The following is a description of a gene set: Any process that increases the concentration of calcium ions in the cytosol. studied in species Homo sapiens Human Gene Set: GOBP_POSITIVE_REGULATION_OF_CYTOSOLIC_CALCIUM_ION_CONCENTRATION, and this is the list of marker genes: CX3CR1, LPAR1, CD36, CACNA2D1, AVPR1B, P2RX3, GPR35, FPR1, CD52, ADCYAP1R1, CCR7, JPH1, KNG1, P2RX5, ACKR3, TACR1, FPR3, NPTN, BAK1, BAX, CD55, RYR2 (NCBI Gene Id 6262), HTR2A, CYSLTR1, EDNRB, PRKG1, TRPC3, SPPL3 (signal peptide peptidase like 3), SLC8A3, CXCR1, CIB2, PIK3CG, BDKRB2, ADRA1D, CHRNA10, TMBIM6, CCR8, GPR6, CCKBR, BDKRB1, ABL2, P2RY4, PTGER1, IL2, HCRT, KISS1, CXCR5, ADRA1A, CHRNA9, CALCA, CCR3, CCR4, CXCL13, P2RY1, CCR6, FFAR4, TBXA2R, GPR32P1, CXCR6, LRP6, C3AR1, SLC8A1, JPH4, CALCR, ADCY5, CD4, JAK2, GALR1, F2R, C1QTNF1, GLP1R, EDN1, CCR2, GNAT2, NMU, AGTR1, PML, SELENOT, TRPM4, CCL28, ABL1, PTGER4, LPAR2, GRIN1, TRPV5, CCL1, NOS1, CCRL2, PROK2, HRH4, S1PR3, GNG3, CACNB3 (NCBI Gene Id 784), GATA2, P2RX7, GIPR, PLA2G1B (NCBI Gene Id 5319), FPR2, GPER1, ESR1, PTGIR, CDK5, LPAR3, GPR32, TRPC5, MCHR1, ADCYAP1, CD38, PKD1, PTGER2, OXT, NMB, CCR5, FKBP1B, GHRL, P2RX2, ASPH, CAV1, TAC1, CACNA1A, CAV3, CXCR2, PLCZ1, CXCR3, PTGFR, CXCR4, ACKR2, FFAR1, C5AR2, AVP, TRPV4, ITPR3, NPY2R, HMGB1, TAC4, SAA1, PTGER3, MIR199A1, AVPR1A, CCR1, ADCY8, XCR1, ITGAV (NCBI Gene Id 7449), CMKLR1 (chemerin chemokine-like receptor 1), GALR2, EDNRA, NPFF, JPH2, DLG4, CD24, ACKR4, GATA1, CCR10, P2RX4, CACNA1C, F2RL1, JPH3, RIC3, SWAP70, TRPC6, ADRA1B, GPR33, EPO, CCR9, PTGDR, C5AR1, BCL2